Given this list of marker genes Trappc12, Cenpk, Cenpa, Senp6, Dlgap5, Cenpw, Rnf4, Cenpc1, Cenph, Pogz, Sugt1, Cenpt, Kntc1, Cenpe, Mis12, Cenpx (NCBI Gene Id 20892), here is a description of the gene set: Mouse Gene Set: GOBP_KINETOCHORE_ASSEMBLY The aggregation, arrangement and bonding together of a set of components to form the kinetochore, a multisubunit complex that is located at the centromeric region of DNA and provides an attachment point for the spindle microtubules. species: Mus musculus